The following is a description of a gene set: studied in species Mus musculus The chemical reactions and pathways involving any one of a family of organic molecules consisting of a pyrimidine base covalently bonded to a sugar deoxyribose (a deoxyribonucleoside). Mouse Gene Set: GOBP_PYRIMIDINE_DEOXYRIBONUCLEOSIDE_METABOLIC_PROCESS, and this is the list of marker genes: Dtymk, Dck, Dpyd (dihydropyrimidine dehydrogenase), Tk1, Tk2